The following is a description of a gene set: Genes predicted to be targets of miRBase v22 microRNA hsa-miR-12130 in miRDB v6.0 with MirTarget v4 prediction scores > 80 (high confidence targets). Human Gene Set: MIR12130 species: Homo sapiens from publication Chen Y, Wang X (PMID 31504780), and this is the list of marker genes: TENM3, SPEN, AP3S1, MT2A (metallothionein 2A), SMURF2, STAM, CDIN1, LMLN, FAM120A, CADPS, MSR1, ARL17B, ASB14, ZNF527, CTSE, SLC35E1, TLN2, BRINP3, RASSF8, MRPL20, GGCX, ASB8, ASB5, MT1X, ZBTB20, MT1A, SOD2, STRN3, MS4A1, ATP5IF1, CEBPG